Given this list of marker genes Gstm3, Gsta2, Cyp2c39, Cyp2b10, Lgalsl, Antxr2, Lgals1, Retsat, Cyp2c55, Fgl1, Anxa5, Actg1, Entpd5, Acot1, Gadd45b, Acot2 (NCBI Gene Id 171210), Cyp7a1, Asns, Hmox1, Cyp2a4, Vnn1, Gstm2, Ces2c, Slco1a4, here is a description of the gene set: Mouse Gene Set: WENG_POR_DOSAGE NADPH-cytochrome P450 reductase (CPR) is an essential component for the function of many enzymes, including microsomal cytochrome P450 (P450) monooxygenases and heme oxygenases. In liver-Cpr-null (with liver-specific Cpr deletion) and Cpr-low (with reduced CPR expression in all organs examined) mouse models, a reduced serum cholesterol level and an induction of hepatic P450s were observed, whereas hepatomegaly and fatty liver were only observed in the liver-Cpr-null model. Our goal was to identify hepatic gene expression changes related to these phenotypes. Cpr-lox mice (with a floxed Cpr gene and normal CPR expression) were used as the control. Through microarray analysis, we identified many genes that were differentially expressed among the three groups of mice. We also recognized the 12 gene ontology terms that contained the most significantly changed gene expression in at least one of the two mouse models. We further uncovered potential mechanisms, such as an increased activation of constitutive androstane receptor and a decreased activation of peroxisomal proliferator-activated receptor-alpha by precursors of cholesterol biosynthesis, that underlie common changes (e.g. induction of multiple P450s and suppression of genes for fatty acid metabolism) in response to CPR loss in the two mouse models. Additionally, we observed model-specific gene expression changes, such as the induction of a fatty-acid translocase (Cd36 antigen) and the suppression of carnitine O-palmitoyltransferase 1 (Cpt1a) and acyl-CoA synthetase long chain family member 1 (Acsl1), that are potentially responsible for the severe hepatic lipidosis and an altered fatty acid profile observed in liver-Cpr-null mice. from publication Weng Y, DiRusso CC, Reilly AA, Black PN, Ding X (PMID 16006652) studied in species Mus musculus Genes up-regulated in liver from mice with liver specific knockout of POR vs mice with reduced expression of POR in all tissues.